The following is a description of a gene set: studied in species Mus musculus from publication Cui A, Huang T, Li S, Ma A, Pérez JL, Sander C, Keskin DB, Wu CJ, Fraenkel E, Hacohen N (PMID 38057668) Genes positively differentially expressed in cell type: MigDC (migratory dendritic cell) upon treatment with cytokine: BAFF in mouse lymph nodes in vivo. Mouse Gene Set: CUI_MIGDC_BAFF_RESPONSE_UP Cytokines mediate cell-cell communication in the immune system and represent important therapeutic targets. A myriad of studies have highlighted their central role in immune function, yet we lack a global view of the cellular responses of each immune cell type to each cytokine. To address this gap, the authors created the Immune Dictionary, a compendium of single-cell transcriptomic profiles of more than 17 immune cell types in response to each of 86 cytokines (>1,400 cytokine-cell type combinations) in mouse lymph nodes in vivo. A cytokine-centric view of the dictionary revealed that most cytokines induce highly cell-type-specific responses. For example, the inflammatory cytokine interleukin-1β induces distinct gene programmes in almost every cell type. A cell-type-centric view of the dictionary identified more than 66 cytokine-driven cellular polarization states across immune cell types, including previously uncharacterized states such as an interleukin-18-induced polyfunctional natural killer cell state., and this is the list of marker genes: S100a11, Ppdpf, Pfn1, Glipr2, Arpc1b, Tubb2b, Gnai2, Fabp5, H2-Aa, Myl12a (myosin, light chain 12A, regulatory, non-sarcomeric), Tagln2, Rbm3, Tmsb10, H2-DMb2, Cd74, Cnn2, H2-DMa, H2-Eb1